The following is a description of a gene set: from publication Cui A, Huang T, Li S, Ma A, Pérez JL, Sander C, Keskin DB, Wu CJ, Fraenkel E, Hacohen N (PMID 38057668) species: Mus musculus Cytokines mediate cell-cell communication in the immune system and represent important therapeutic targets. A myriad of studies have highlighted their central role in immune function, yet we lack a global view of the cellular responses of each immune cell type to each cytokine. To address this gap, the authors created the Immune Dictionary, a compendium of single-cell transcriptomic profiles of more than 17 immune cell types in response to each of 86 cytokines (>1,400 cytokine-cell type combinations) in mouse lymph nodes in vivo. A cytokine-centric view of the dictionary revealed that most cytokines induce highly cell-type-specific responses. For example, the inflammatory cytokine interleukin-1β induces distinct gene programmes in almost every cell type. A cell-type-centric view of the dictionary identified more than 66 cytokine-driven cellular polarization states across immune cell types, including previously uncharacterized states such as an interleukin-18-induced polyfunctional natural killer cell state. Genes positively differentially expressed in cell type: pDC (plasmacytoid dendritic cell) upon treatment with cytokine: IL-1β in mouse lymph nodes in vivo. Mouse Gene Set: CUI_PDC_IL1B_RESPONSE_UP, and this is the list of marker genes: Dntt, Dad1, Pfn1, Pdcd4, Klf13, Coro1a, Cfl1, Ifnar1, Lrp10, Cd38, Gsr, Mpeg1, Cdh1, H2-T23, Fkbp5, Bcl3, Csf2rb2, Sub1, Rnf19b, Socs3, Adipor2, Treml2, Capzb, Ccl5, Fgfr1, Gbp7, Trp53i11, P2ry10, Stat3, Ccnd3, Dhx9, Lifr, Fbl, H2aj, Sla2, Vps8, Ptprc, Gpr171, Sell, Napsa, Filip1l, Ubl3, Tsr1, Hnrnpa3, Eif1, Ctnnd2, Tmed9, Sla, Nme1, Lyn, Mif4gd, Psme2, Atp2b4, Ncl, Rassf5, Pim1, Klk1b27, Klk1, Laptm5, Mgl2, Runx1, Jak2, Sh3pxd2a, Cebpb, Srsf3, Tspo, Reep5 (NCBI Gene Id 98127), Slc25a12, Tsc22d3, Rrbp1, Cd200r1, Dynlt1f, Cyth1, Gpx4, Calm1, Adpgk, Cd82, Psma3, Cdkn2d, Ppp1r21, Selplg, Clec10a, Eif5a, Hexim1, Nedd8, Plcd3, Zfp36l2, Agpat5 (NCBI Gene Id 68630), Srgn, Cct3, Slc7a5, Slc3a2, Grn, Mt1, Ddr1, H3f3a, Panx1, Slamf9, Sdc3, Pak2, Slc30a4, Jtb, Cytip, Ptpn1, Plac8, Rwdd1, Wfdc17, M6pr, Rbm3, Angptl7, Paqr5 (progestin and adipoQ receptor family member V), Rftn1